The following is a description of a gene set: Mitochondrial translation studied in species Homo sapiens Human Gene Set: REACTOME_MITOCHONDRIAL_TRANSLATION, and this is the list of marker genes: MRPS17, MRPS16, KGD4, MRPL23, MRPL13, MRPS28, MRPL12 (mitochondrial ribosomal protein L12), MRPL32, MRPS35, MRPL22, MRPL33, MRPL3, OXA1L, MRPL9, MRPS5, MRPL28, MRPL42, MRPL36, MRPS12, MRRF, MRPL39, MRPS22 (NCBI Gene Id 64953), MRPS18B, TUFM, MRPL24, MRPL10, GFM1, MRPL35, MRPS31, MTRF1L (mitochondrial translation release factor 1 like), MRPS21, TSFM, MRPS23, MRPS34, MRPS6, MRPL18, MRPL50, MRPL43, MRPL49, MRPL51, MRPS14, MRPL4, MRPL55, MRPS11, MRPL30, PTCD3, MRPS7, MRPL2, CHCHD1, MRPL45, GFM2, MT-RNR1, MRPL48, AURKAIP1, DAP3, MRPL58, MRPL37, MRPL40, MRPL57, MRPL52 (NCBI Gene Id 122704), MRPL11, MRPS24, MRPL21, MTIF2, MRPL15, MRPS26, MRPL47, ERAL1, MRPS33, MTIF3 (NCBI Gene Id 219402), MRPL54, MRPL20, MRPS10, MRPS9, MRPS15, MRPL27, MRPL46, MRPL41, MRPS30, MRPL14, MRPL53, MRPL16, MRPL34, MRPS18A, MRPL1, MRPL17, MRPL19, MT-RNR2, MRPS27, MRPL44, MRPS25, MTFMT, MRPS18C, MRPL38, MRPS2, GADD45GIP1